The following is a description of a gene set: Enables the transmembrane transfer of a cation by a channel that opens when intracellular cAMP has been bound by the channel complex or one of its constituent parts. Human Gene Set: GOMF_INTRACELLULARLY_CAMP_ACTIVATED_CATION_CHANNEL_ACTIVITY species: Homo sapiens, and this is the list of marker genes: HCN4, CNGA3, CNGA2, CNGA1, HCN2, CNGA4, CNGB3 (cyclic nucleotide gated channel subunit beta 3), CNGB1, HCN1